Given this list of marker genes Nfkbia, Psen1, Tgfb1, Sumo1, Epm2a, Hsp90aa1, Hnf4a, Ptpn5, Jak2, Ep300, Nutf2, Ran, Akap5, Prkcd, Pik3r1, Il6, Mdfic (NCBI Gene Id 16543), Pkig, Nup58, Bag3, Nf1, Pik3r2, Mavs, Lep (NCBI Gene Id 16846), Tek, Cdh1, Rab23, Gli3, Mapk1, Zic1, Efcab7, Gper1, Uaca, Ptpn22, Zc3h12a, Nutf2-ps1, Smo, Agtr2, Trim28, Xbp1, Dmap1, Cdk1, Tpr, Gbp4, Ect2, Angpt1, Ei24, Apod, Nup62, Prkcq, Ifng, Sirt6, Rbm22, Flna, Pkia, Zpr1, Shh, Akap1, Tnfrsf1a, Nolc1, Hdac3, Hm629797, Chp2, Ipo5, Cd36, Jup, Nup54, Hcls1, Ywhab, Hyal2, Ubr5, Cwh43, Cabp1, Tardbp, Ptgs2, Ufm1, Chp1, Prkd1, Bmp4, Brca1 (NCBI Gene Id 12189), Hsp90ab1, Mapk14, Fermt1, here is a description of the gene set: Mouse Gene Set: GOBP_REGULATION_OF_PROTEIN_IMPORT_INTO_NUCLEUS studied in species Mus musculus Any process that modulates the frequency, rate or extent of movement of proteins from the cytoplasm to the nucleus.